The following is a description of a gene set: The appearance of a endothelin due to biosynthesis or secretion following a cellular stimulus, resulting in an increase in its intracellular or extracellular levels. Endothelins are endothelium-derived vasoactive peptides involved in a variety of biological functions. Mouse Gene Set: GOBP_ENDOTHELIN_PRODUCTION species: Mus musculus, and this is the list of marker genes: Kcnj8, Ptger4, App, Ager, Sulf2